Given this list of marker genes SCARF1, NLGN3, DRAM1, RNF148, KCNK1, URAD, NOS3, HAPLN2, TIFA, PSD, HHIPL1, FAIM2, SEC16B (SEC16 homolog B, endoplasmic reticulum export factor), SCTR, TMEM184A, MAGEA9, ST6GALNAC5, POLG, CLDN18, MYL4, ARVCF, HDGFL1, IGDCC4, EBF2, PCDHB7, H6PD, C1QTNF2, PRDM16, LEFTY1, BARX2, SNTA1, HOXA7, HS6ST2, DPH2, ARHGDIB, ANKRD34A, IFT88, KRTAP5-3, ISLR, GPR25, LMOD1, E4F1, ADAMTS4, PLAAT3, OSTN, SLC16A9, MIR302D, DIO1, FEM1A, SCGB2A2, DUOX2, DCAF11, SYP, RTL4, DDR2, ADAMTS7, TRIM6, CLEC11A, CNTN2, SNCA, ANTXRL, KCNT1, MRAP, NHEJ1, MIR183, ANO7, B3GLCT, ALPK3, LRRC7, AATK, HSPB1, CCR10, MIR194-1, SLC39A3, SPRR4, GJA10, DUSP28, PPP1R27, MATN2, WWTR1, EPHA6, KLHL31, TPH2, SPHK1, DLL3, PAQR9, A4GNT, DOC2B, RFX6, RAPGEF3, KIF17, TMEM217, CXCL14, FCMR, NPHP4, MAB21L3, SLC35G2, GNG8 (NCBI Gene Id 94235, G protein subunit gamma 8), TIMP3, ACMSD, ARFGEF2, GABRR3, GARIN1B, FABP12, MOXD1 (NCBI Gene Id 26002), CD163, CDC42EP2, PNCK, CCS, SPATS2L, RTN1, IRGC, EMX1, LEMD1, FLVCR2, ADRA1D, FBXO43, CETN1, ZBTB8OS (zinc finger and BTB domain containing 8 opposite strand), KRTAP4-6, CHST1, ADAMTS16, RPS9 (NCBI Gene Id 6203), TMCC2, CLDN14, VMAC, RFX4, UNC5B, CYP11B1, here is a description of the gene set: The goal was to determine how IL-12 affects gene expression by murine CTL. Human Gene Set: GSE13173_UNTREATED_VS_IL12_TREATED_ACT_CD8_TCELL_UP from publication Markiewicz MA, Wise EL, Buchwald ZS, Cheney EE, Hansen TH, Suri A, Cemerski S, Allen PM, Shaw AS (PMID 19155481) species: Homo sapiens Genes up-regulated in splenocytes from OT-1 TCR transgenic mice: control versus IL-12 treatment.